The following is a description of a gene set: Polymerase switching Human Gene Set: REACTOME_POLYMERASE_SWITCHING species: Homo sapiens, and this is the list of marker genes: RFC1, POLA2, POLD2, PRIM1, RFC2, POLD1, POLA1, PCNA, PRIM2, RFC5, RFC4, POLD3, RFC3, POLD4